Given this list of marker genes MSMO1, MYBL2, SLC30A1, LOX, SOD2, MAPK7, DPP4, VAPB, PDGFC, NCL, RDH14, GRB10, UPP1, HSPA5, KCNMA1, MYOD1, DHCR7 (NCBI Gene Id 6589), MSANTD3, PTPN12, CITED2, UBE2E1, PEX26, GSTA1, GNPDA1, CIDEB, SNX9, SAP30BP, ANXA4, RAB20, AP2B1, TOMM20, CDC34, KPNB1, ITGB4, PLOD2, CPNE1, GTPBP2, DDX19B, NT5E, ENTREP1 (NCBI Gene Id 9413), PPP1R3C, OSER1, SIRPA, PEA15, HILPDA, ADAR, UBE2O, ARHGAP8, DDX41, KDM2B, TRNAU1AP (NCBI Gene Id 54952), ASPH (aspartate beta-hydroxylase), YPEL5, ZFP36, IFNGR1, ZBTB47, SPATA20, MAP2K6, IGFBP3, SERPINE1, STBD1, SNX10 (NCBI Gene Id 29887), SLC35E1, TLNRD1, CPD, AKAP12, NDRG2, RFX3, KPNA4, TFG, STOM, RALGDS, SNX4, CTSL, NIT1, CANX, TCEA3, PTPRU, SOX12 (SRY-box transcription factor 12), GRSF1, NUPR1, ZNF395, CHPT1, PFDN1, STXBP2, AGPAT2, IMP3, CDC42, MCL1, ARHGEF2, CORO1A, AP3M2, GAL3ST1, SNTA1, SGCE, ALDOC (NCBI Gene Id 230), CD2BP2, H3-3B, DUSP1, MAP1LC3A, LARP6, BNIP3, PLIN2, LRP1, P4HA1, CA12, MTCL1, HOOK2, PJA2, ORMDL1, ATP1B3, RBM12, ENOSF1, KHDRBS3, TMEM30A, TSKU, LAMC1, IL9R, NDRG1, C2orf49, SESN2, RIPK4, HDHD5, CAV1, TSC22D3, SYT13 (NCBI Gene Id 57586), RSL24D1, MED10, HLF, GM2A, SQLE, UGP2, HIF1A, PPP1R15A, FBXO8, PSMD6, ENO2, FAM162A, FASN, ANGPTL4, SLC2A1, NARS1, OBSL1, SERBP1, P4HB, SDCBP, AK4, NOL3, CSDE1, BNIP3L (NCBI Gene Id 9257), MLF1, PLCD1, ATF7IP, SERGEF, CD9, EIF2S2, HLA-A, ADD3, GPATCH8, STC2, RYBP, STAU1, SCD, MVK, NFKBIA, CKB, WAPL, IMMP2L, PIM2 (Pim-2 proto-oncogene, serine/threonine kinase), NMT1, RER1, AMH, RHBDD3, PKD1, MAGT1, SRRM2, GPRC5A, DCAF6, RNF114, LSR, ARL1, PI4K2A, HMOX1, PSMB10, FEZ1, SLC30A9, MDK, STAMBP (STAM binding protein), TGM2, NEK6, HOXA4, GADD45B, SERTAD2, SLC3A2, UGCG, BLVRB, XPNPEP1, KCMF1, CDK8, PPP1R11, here is a description of the gene set: The von Hippel-Lindau tumor suppressor, pVHL, is a key player in one of the best characterized hypoxia signaling pathways, the VHL-hypoxia-inducible factor (VHL-HIF) pathway. To better understand the role of VHL in the hypoxia signaling pathways of tumor cells, we used serial analysis of gene expression (SAGE) to investigate hypoxia-regulated gene expression in renal carcinoma cells (786-0), with and without VHL. The gene expression profiles of the cancer cells were compared to SAGE profiles from normal renal proximal tubule cells grown under both normoxia and hypoxia. The data suggest that the role of VHL as a tumor suppressor may be more complex than previously thought. Further, the data reveal that renal carcinoma cells have evolved an alternative hypoxia signaling pathway(s) compared with normal renal cells. These alternative hypoxia pathways demonstrate VHL-dependent and VHL-independent regulation. The genes involved in such pathways include those with potential importance in the physiological and pathological regulation of tumor growth and angiogenesis. Some of the genes identified as showing overexpression in the cancer cells, particularly those encoding secreted or membrane-bound proteins, could be potential biomarkers for tumors or targets for rational therapeutics that are dependent on VHL status. Genes up-regulated in RPTEC cells (normal kidney) by hypoxia. species: Homo sapiens from publication Jiang Y, Zhang W, Kondo K, Klco JM, St  Martin TB, Dufault MR, Madden SL, Kaelin WG Jr, Nacht M (PMID 12692265) Human Gene Set: JIANG_HYPOXIA_NORMAL